The following is a description of a gene set: Genes predicted to be targets of miRBase v22 microRNA hsa-miR-138-5p in miRDB v6.0 with MirTarget v4 prediction scores > 80 (high confidence targets). from publication Chen Y, Wang X (PMID 31504780) Human Gene Set: MIR138_5P species: Homo sapiens, and this is the list of marker genes: SLC2A10, SCRN1, ARRDC3, ARHGAP32, LMAN1, PIP4K2C, ZSCAN22, DCP1A, PLXNB2, RPS6KA1, PDIK1L (NCBI Gene Id 149420), PRRT4, PPARGC1A, PACSIN2, PDE7B, SERTAD4, CLNS1A, ZNF275, RAD51D, MTUS2, CLMP, ITGAL, SPTB, CA3, AKAP11, KIAA0930, KDELR2, LIN9, SOCS5, CORIN, ZEB2, ILDR2, LYPLA1 (lysophospholipase 1), CSRP2, AMMECR1, KLF11, TMOD2, SIN3A, CCND3, NRM, JMJD1C, LZTS3, SOBP, CDK6, L3MBTL3, EPHA8, LSM14A, FAM169A, SESN3 (sestrin 3), NFIB, FOXC1, PDE3A, THRAP3, UNC5A, STXBP5, JAZF1, CNOT8, RMND5A, CASTOR2, KMT2C, MAPDA, CENPN, GTF3C3, TMTC4, SIRT1, GNAI2, CELF5, CALN1, ARPIN, LPAR4, ARHGAP6, TULP4, TRPS1 (NCBI Gene Id 7227), JOSD1, NPPC, LIMCH1, RIMS2, ERI1, MRM3, SH2B3, SLCO3A1, ZFAT, SLC41A1, KBTBD4, AGO1, NFIX, H3-3B, SULF2, PAPPA, TMEM198, EZH2, RCAN2, HK1, MIEF2, KMT5B, PPIP5K1, SEH1L, ACP7, BLTP3A, C6orf47, APPBP2, SCN8A (sodium voltage-gated channel alpha subunit 8), DNAJB6, RASL12, TTLL12, MAST4, MXD1, TEAD1, BAZ1B, NSFL1C, ZNF385A, CLEC1A, KLHL18, ATP11C, SNCAIP, CNOT6L, G6PD, FAM210B, MAN2A1, LAYN, NKAIN1, RARA, UNC5D, AGO4, NBEA, PPARD, BCL11A, RB1CC1, ANK1, AHCYL2, VIM, HECTD2, THAP11, FAM83D, RIBC1, CD34, ADCYAP1R1, RPRD1B, RNF38, ACVR2B, KIAA1958, NSMF, S100A2, CLN5, PTK2, VEZF1, NEUROD1, CREB1, DNAH12, FERMT2, CLVS1, SENP1, FRMD5, DCUN1D4, FOXP4, CCDC85C, SLC6A17, NKAPD1, ROCK2, UPF2, THRB, SIGLECL1, SEZ6L2, VSTM2L, SYT13, ARHGAP42, ZFP36L2 (NCBI Gene Id 96706), MTCL2, ZER1, PSD2, CALHM5, NINJ1, TENT4B, PTPN4, FEM1C, SLC6A8, SH3GL2, EID1, TRAM1, SORBS2, VSTM4, KANK1, UBP1 (NCBI Gene Id 7342), SLC35F1, DTX4, PWWP2A, GNG2, ADGRA2, KLF12 (NCBI Gene Id 82238), CLIP1, DMKN, CNOT9, USP10, HIF1AN, GGCX, ST6GALNAC4, RASSF8, DEK, BPNT2, VPS26A, PRPF40A, RELN, ZNF148, GTPBP1, TIPARP, RHOC, CLOCK, KDM5A, MTF2, DESI2